The following is a description of a gene set: Any process that results in a change in state or activity of an organism (in terms of movement, secretion, enzyme production, gene expression, etc.) as a result of a inadequate blood supply. Mouse Gene Set: GOBP_RESPONSE_TO_ISCHEMIA species: Mus musculus, and this is the list of marker genes: Aqp3, Uchl1, Eef2k, Egr1, Sqstm1, Ndnf, Slc26a5, Bcl2, Tigar, Camk2a, Ptk2b, Rest, Rela, Casr, Nqo1, Bves, Cib1, Hyou1, Cx3cl1, Pink1, Trem2, Faim2, Sos1, Nol3, Hk1, Ppif, Sirt5, Cav1, Gja1, Cpeb4, Cav3, Bcl2l2, Mef2c, Nppc, P2rx4, Kcnj8, Map2k3, P2rx2, Bcl2l1, Abraxas2, Rcan1, Aifm1, Rock2, Map2k6, Kcnj11, Pik3cb, Gpr31b, Slc8a2 (NCBI Gene Id 20542), Mir874, Cx3cr1, Stat3, Csf1r, Npr3, Mlycd, Trp53, Casp9, Map2k2, Hk2, Gjb2, Csf1, Panx2, Nfe2l2, Panx1, Per2, Map3k5 (mitogen-activated protein kinase kinase kinase 5)